The following is a description of a gene set: species: Mus musculus Mouse Gene Set: GOBP_MAMMARY_GLAND_EPITHELIUM_DEVELOPMENT The process whose specific outcome is the progression of the mammary gland epithelium over time, from its formation to the mature structure. The mammary gland is a large compound sebaceous gland that in female mammals is modified to secrete milk., and this is the list of marker genes: Id2, Jak2, Csmd1, Fgf2, Pml, Csf1, Etv4, Hif1a, Ncoa3, Stat6, Pthlh, Wnt3, Msx1 (msh homeobox 1), Ccl11, Tgfb1 (transforming growth factor, beta 1), Atp2c2, Src, Tbx3, Gli2, Rtn4, Chuk, Ccnd1, Mapk1, Elf5, Tfap2c, Scrib, Agap2, Zfas1, Zfp703, Fgf10, Ptch1, Mst1, Prlr, Perp, Wnt2, Smo (NCBI Gene Id 319757), Msx2, Wnt4, Vdr, Foxb1, Gpx1, Nr3c1, Bax, Ntn1, Phb2, Hoxa5, Ddr1, Lrp5, Btrc, Pinc, Brca2, Erbb4, Kdm5b, Wnt5a (NCBI Gene Id 77565), Foxf1, Lats1, Pgr, Cdkn2a, Orai1, Lrp6, Stat5a, Gata3, Cav3, Cebpb, Sostdc1, Etv5, Ar, Robo1, Slc12a2, Areg, Rreb1 (NCBI Gene Id 68750), Slit2, Epha2, Lbh, Pygo2, Med1, Irf6, Fgfr2, Iqgap3, Deaf1, Tnfsf11, Esr1